The following is a description of a gene set: part of: Metabolism of water-soluble vitamins and cofactors electronically inferred by orthology from the curated human pathway studied in species Mus musculus Reactome Pathway: Cobalamin (Cbl, vitamin B12) transport and metabolism This event has been computationally inferred from an event that has been demonstrated in another species.<p>The inference is based on the homology mapping from PANTHER. Briefly, reactions for which all involved PhysicalEntities (in input, output and catalyst) have a mapped orthologue/paralogue (for complexes at least 75% of components must have a mapping) are inferred to the other species., and this is the list of marker genes: Abcd4, Mtrr, Cblif, Mmab, Gm19410, Tcn2, Mmachc